The following is a description of a gene set: studied in species Homo sapiens Human Gene Set: GOBP_NEGATIVE_REGULATION_BY_HOST_OF_VIRAL_TRANSCRIPTION Any process in which a host organism stops, prevents, or reduces the frequency, rate or extent of viral transcription., and this is the list of marker genes: ZNF639, INPP5K, CCL3, JUN, BRD4, HDAC1, TFAP4, PSMC3, REST, CCL5, CCL4, HMGA2 (NCBI Gene Id 8091), POU2F3, TARDBP